Given this list of marker genes FAM21FP, SMOC2, BST1, NECAB1, RAET1E, LRRN4, FAM133CP, CBLL1-AS1, INMT, MKRN9P, TBX18, RAB6D, CCDC80, KCTD4, ENSG00000268686, BCHE, IL18, OLFML1, SPATA41, UNC5B-AS1, RN7SL689P, RAET1G, ZNF676, MSLN, ANXA3, CBLN2, PLA2G2A, LINC00607, SPMIP7, SPRR2B, ARL14EP-DT, CA9, PRG4, KLK7, CALB2, MEDAG, S100A10, AQP9, NPNT, ENSG00000212458, LINC00922, EPGN, TGM1, ITLN1, KCNT2, GUCA1A, KLK5, CCNYL1, TRPA1, TNFRSF8, PHYHIP, CPA4, here is a description of the gene set: species: Homo sapiens from publication Cao J, O'Day DR, Pliner HA, Kingsley PD, Deng M, Daza RM, Zager MA, Aldinger KA, Blecher-Gonen R, Zhang F, Spielmann M, Palis J, Doherty D, Steemers FJ, Glass IA, Trapnell C, Shendure J (PMID 33184181) Human Gene Set: DESCARTES_MAIN_FETAL_EPICARDIAL_FAT_CELLS The gene expression program underlying the specification of human cell types is of fundamental interest. The study authors generated human cell atlases of gene expression and chromatin accessibility in fetal tissues. For gene expression, the study authors applied three-level combinatorial indexing to >110 samples representing 15 organs, ultimately profiling ~4 million single cells. The study authors leveraged the literature and other atlases to identify and annotate hundreds of cell types and subtypes, both within and across tissues. Our analyses focused on organ-specific specializations of broadly distributed cell types (such as blood, endothelial, and epithelial), sites of fetal erythropoiesis (which notably included the adrenal gland), and integration with mouse developmental atlases (such as conserved specification of blood cells). These data represent a rich resource for the exploration of in vivo human gene expression in diverse tissues and cell types. Marker genes curated from the annotated cluster as represented in the Descartes Human Gene Expression During Development database.